The following is a description of a gene set: species: Mus musculus Mouse Gene Set: GOMF_THIAMINE_TRANSMEMBRANE_TRANSPORTER_ACTIVITY Enables the transfer of thiamine from one side of a membrane to the other. Thiamine is vitamin B1, a water soluble vitamin present in fresh vegetables and meats, especially liver., and this is the list of marker genes: Slc22a1 (solute carrier family 22 (organic cation transporter), member 1), Slc47a1, Slc25a19, Slc22a2, Slc19a3, Slc19a2, Slc47a2, Slc44a4